The following is a description of a gene set: Human Gene Set: GSE29617_CTRL_VS_DAY7_TIV_FLU_VACCINE_PBMC_2008_DN Systems vaccinology has emerged as an interdisciplinary field that combines systems wide measurements and network and predictive modeling applied to vaccinology. Here we used the systems vaccinology approach to study the molecular mechanisms underlying th species: Homo sapiens from publication Nakaya HI, Wrammert J, Lee EK, Racioppi L, Marie-Kunze S, Haining WN, Means AR, Kasturi SP, Khan N, Li GM, McCausland M, Kanchan V, Kokko KE, Li S, Elbein R, Mehta AK, Aderem A, Subbarao K, Ahmed R, Pulendran B (PMID 21743478) Genes down-regulated in comparison of peripheral blood mononuclear cells (PBMC) from TIV influenza vaccinee pre-vaccination versus those at day 7 post-vaccination., and this is the list of marker genes: LMAN2, UQCR10, CYSLTR2, CCT7, TGM2 (NCBI Gene Id 7052), NSMCE4A, MED13, MTRF1, HOMER1, GLDC, ORM1, IGKV1D-13, MRPL24, PDIA4, RPAP1, IGLV1-44, IGKV3-20, TNFRSF17, BLM, SLC39A7, TRAPPC12, AP4E1, KIF3B (kinesin family member 3B), SSR3, HDLBP, IGLV3-19, HM13 (histocompatibility minor 13), METTL8, UQCRQ, ZNF692, STAP1, UBXN8, CCT4, GPR171, TFB1M, DARS1, FBH1, GALM, MCM3, ZKSCAN1, PDCD11, SLC44A1, AQP3, APEH, CLPTM1L, PSME3IP1, POU5F1B, RPS27L, MRI1, CRELD2, CDCA7, ZNF585B, MEN1, FKBP2, SRP54, BABAM1, FAM219B, HIBCH, RABAC1, HSP90B1, STT3A, PRR14, MIS18A, SLC26A2, SPOP, BMS1P20, LMAN2L, CA9, PDIA5, MAN1A1, PRDX4, PIGU, SEC61A1, NSUN5, CD27, CEBPA-DT, PPP1R3E, SEL1L3, FASTKD1 (FAST kinase domains 1), IGLV6-57 (immunoglobulin lambda variable 6-57), METTL3, ITM2C, FLAD1, GOLGA6L2, IFNA7, PKD1P1, NDUFAB1, MRPL37, OIP5, MRTO4 (NCBI Gene Id 94394), MANF, AARS1, PABPC1L, HAX1, GNPAT, WASHC3, HMOX2, FAM120B, MID1, GATD3, CREB3, H2AC18, ATXN2, NT5DC1, ZWINT, PPIB, CACYBP, SLAMF6, CD38, ISG20, UQCC1, PRDX1, NSUN5P1, SPCS1, ADAM19, SEC61B, PPP1R21, METTL5, ALG14, NUDT13, ALG6, NDUFB10, SPATS2, TTF1, CAV1, ECH1, SETD5, MAP3K12, ZBTB8OS, SEC11C, DDOST, GGH, AURKAIP1, MRPS12, BORCS8, PDIA6, PPP1R7, MED24, MYDGF (NCBI Gene Id 80302), COCH, HDDC3, SIGLEC9 (NCBI Gene Id 27180), MAP3K7, EAF2 (ELL associated factor 2), MZB1, MAMSTR, NDUFB4, NAA20, QRSL1, RRM2, MCCC2, RPA3, MARK2, PLPP5, TNFRSF13B, IARS1, C11orf24, CFAP298, MITD1, MTHFD1, MCM7, KLHL14, NVL, KLHDC3, UBR5, TAS1R1 (NCBI Gene Id 80835), ATP5PF, MARS1, DDB1, HYOU1 (hypoxia up-regulated 1), RACK1, PREB, GK, ST6GAL1, POU2AF1, NSUN5P2, GUSBP11, GMPPB, IGLJ3, TYSND1, PMS1, ALDH18A1, GPD2, MAGED1, DGUOK, SDHAF3, KDELR2, IFI27 (interferon alpha inducible protein 27), HERC4, SDF2L1, SELENOS, OSTC, H1-3, TCTN2